Given this list of marker genes TTC21A, EPN1, H2BC21, SNORA63B, STX10, IKBKB-DT, RNU4-2, MAT2A, B2M (NCBI Gene Id 567), S100A16, H2BC12 (NCBI Gene Id 85236), PKM, RPL13A, PRDX5, C11orf98, HNRNPA1, PPP1R35-AS1, GPX1, FOSL2, SNORD12B, ERCC1, EXOSC6, SNORA44, LINC02939, SNAPC5, SNORA31, HSPA8, ACTB, S100A11, MALAT1, MFSD11, IKBKB, DNAJB1, KIF22, CD68, RBCK1, SNORD32A (small nucleolar RNA, C/D box 32A), EEF1A1, SNORD12, ESRRA, MFSD12, RNU6-1305P, NR4A2, RCC1, VMP1, RPL8, SAT1-DT, ZC3H12A, TPM4, SAMD1, SLC38A2-AS1, PGP, SLC20A1, NR4A1, H4C1, PLSCR1, SNORD65, FOSL2-AS1, SNORD33, ABCA7, LDLR, IQCN, GAS5, IER2, SOCS3-DT, H2AC11, CARS2, HOOK2, EIF4A2, ADAMTSL4-AS1, SAT1, IGF1R, B4GALT1-AS1, SGF29 (NCBI Gene Id 112869), SNORA61, SFPQ, C5orf24, CD55, SLC38A2, H2AC20, NEAT1 (nuclear paraspeckle assembly transcript 1), MIR3143, TRMT112, SNORD4B, SRSF2, TPT1, MIDN, PATL2, PPIA, RGL2, KRT8, ING1, H2AC12, HSPA1B, FLOT1, NUP214, ANXA2, SLC50A1, GRAMD1B, C11orf54, IER3-AS1, JUNB, MIR5087, ACTG1, RBM4, MIR3193, H2BC11, MAN2C1, here is a description of the gene set: Human Gene Set: MAPK3_TARGET_GENES Genes containing one or more binding sites for (MAPK3) in their promoter regions (TSS -1000,+100 bp) as identified by GTRD version 20.06 ChIP-seq harmonization. from publication Yevshin I, Sharipov R, Kolmykov S, Kondrakhin Y, Kolpakov F (PMID 30445619) species: Homo sapiens